The following is a description of a gene set: part of: mRNA Splicing This event has been computationally inferred from an event that has been demonstrated in another species.<p>The inference is based on the homology mapping from PANTHER. Briefly, reactions for which all involved PhysicalEntities (in input, output and catalyst) have a mapped orthologue/paralogue (for complexes at least 75% of components must have a mapping) are inferred to the other species. studied in species Mus musculus Reactome Pathway: mRNA Splicing - Minor Pathway electronically inferred by orthology from the curated human pathway, and this is the list of marker genes: Polr2b, Gtf2f2, Zcrb1, Snrpg, Ddx23, Zmat5, Polr2k, Polr2i, Snrnp40, Sf3b5, Snrnp25, Polr2l, Eftud2, Polr2e, Polr2c, Snrnp35, Polr2f, Polr2a, Gtf2f1, Snrpf